The following is a description of a gene set: species: Homo sapiens Any process that modulates the frequency, rate or extent of lamellipodium morphogenesis. Human Gene Set: GOBP_REGULATION_OF_LAMELLIPODIUM_MORPHOGENESIS, and this is the list of marker genes: CD44, KANK1, ARHGEF7, ARPIN, SRC (SRC proto-oncogene, non-receptor tyrosine kinase), PDPN, ENPP2, CORO1C, CORO1B, VIL1, RREB1